Given this list of marker genes SLC1A5, SLC25A13, SLC25A22, SLC25A12, SLC13A3, SLC25A11, UCP2, SLC25A10, SLC1A4, SLC13A2, SLC13A5, SLC1A1, SLC1A6, SLC16A1, SLC25A18, here is a description of the gene set: Enables the transfer of C4-dicarboxylate from one side of a membrane to the other. species: Homo sapiens Human Gene Set: GOMF_C4_DICARBOXYLATE_TRANSMEMBRANE_TRANSPORTER_ACTIVITY